The following is a description of a gene set: species: Homo sapiens Any process that modulates the frequency, rate or extent of mesoderm cell fate specification. Human Gene Set: GOBP_REGULATION_OF_MESODERMAL_CELL_FATE_SPECIFICATION, and this is the list of marker genes: SFRP2, BMPR1A, DKK1, WNT3A, FGFR1, MESP1